The following is a description of a gene set: from publication Chen Y, Wang X (PMID 31504780) studied in species Homo sapiens Human Gene Set: MIR365A_5P Genes predicted to be targets of miRBase v22 microRNA hsa-miR-365a-5p in miRDB v6.0 with MirTarget v4 prediction scores > 80 (high confidence targets)., and this is the list of marker genes: TANC1, RBM46, MYF5, PRTFDC1, HMGA2, USP12, SIM2, POGZ, MOCS2, SLC37A2, HOMEZ, MAPT, ALMS1, PRDM6, DUS4L, PRX, USP34, CPA3, SMAD2, GAB2, ZCCHC14, PHC2, DEGS1, CCDC47, SLC24A3, IQCK, UBR3, SYT2, NUDT12, EPOR